Given this list of marker genes TLR5, EIF2AK3, ATP6V1B2, EGR2, ZMIZ1-AS1, EFR3A, UBR7, TDRD9, FAM131A, ATP6V1D, RRAD (RRAD, Ras related glycolysis inhibitor and calcium channel regulator), SLCO4A1, SMIM13, TCEAL3, PPARG (NCBI Gene Id 5468), NRIP3, DPH5, PISD, MMP1, FKBP15, ABCB4, BLMH, SDSL, SNX8, ACVR1, CAMTA2, USP53, ATP6V1G1, CTSL, MAP4K3, GALNT11, TOMM34, MOB1B, SLC9B2, SPP1, DYNLT2B, CRY1, AGAP3, SERTAD2, PACC1, CRTAM, LPL, COL15A1, BCAR3, DDIT3, SNX33, EEA1, TMEM65 (NCBI Gene Id 286052), UBXN7, GNA13, OLIG2 (NCBI Gene Id 10215), ENSG00000215022, NPC1, DCUN1D4, RRAGD, RHOBTB3, AMZ2P1, KLHL21, SIGLEC15, LINC-PINT, DCSTAMP, ST18, RIOX1, HES4, CSTB, TRPM7, ASPH, PRKAG2 (protein kinase AMP-activated non-catalytic subunit gamma 2), LGALS3, DTL, LONRF3, PTPRE, PPFIA1, SPRY2, LINC00856, TBC1D2, RRAGC, TUT7, LRRC8B, CDC42EP3, MELTF, S1PR3, CCR1, TMEM181, ATF3, ZC3HC1, NUDT4, ACSL3, SPRING1, SPAG5, WDFY1, GFOD1, TEX10, CHSY1, CEBPB, ADCK2, SNX9, DAB2, LINC01010, PHF13, GNPDA1, SLC3A2, RMC1, MT1E, CORO1C, ATP6V0D2, UPP1, PI4K2A, PLEKHM1, NAA50, CSF1, LHFPL2, STX4, STX3, MT1X, THAP4, WDR91, ITGAX, BANP, ANKRD10, LBX2-AS1, KLHL6, LYSET, SNAPC1, SPINK1, LONP1, PPP2R5A, MMP19, MT2A, DYRK3, PHACTR2, PLCXD1, ANKRD28, MT1HL1 (NCBI Gene Id 645745), MRGBP, ACOX3, BRI3, SOS1, RRN3P3, BHLHE40, TBC1D7, FBXL5, RASGEF1B, RABGEF1, CD84, SCG5, TLNRD1, HTRA4, RLF, ST3GAL6, TCEAL9, ZNF674-AS1, SCARB2, TMEM38B (transmembrane protein 38B), NR4A2, MAFK, STARD8, RBM15, RGS1, GPCPD1, EDN1, SNUPN, AKIRIN2, GEM, ZNF318, TNFSF14, ZCCHC2, ZSCAN5A, HAVCR2, TNFSF15, NRROS, FNIP2, LY9, SGK1, MOAP1, TMEM268, SYN2, ATP6V1H, UBASH3B, RNF19A, COPRS, CALU, DUSP14 (NCBI Gene Id 116242), PLEKHM2 (pleckstrin homology and RUN domain containing M2), CLN8, ZBTB43, IL36RN, GTF2A1, S100A2, SOWAHC, SH3BP5, SERPINE1, NEU1 (neuraminidase 1), LBH, PLPP3, TRIB1, RHOB, here is a description of the gene set: Human Gene Set: GSE9988_LOW_LPS_VS_ANTI_TREM1_AND_LPS_MONOCYTE_DN Genes down-regulated in comparison of monocytes treated with 1 ng/ml LPS (TLR4 agonist) versus monocytes treated with anti-TREM1 and 5000 ng/ml LPS (TLR4 agonist). studied in species Homo sapiens from publication Dower K, Ellis DK, Saraf K, Jelinsky SA, Lin LL (PMID 18292579) TREM-1 is an orphan immunoreceptor expressed on monocytes, macrophages, and neutrophils. TREM-1 associates with and signals via the adapter protein DAP12/TYROBP, which contains an immunoreceptor tyrosine-based activation motif (ITAM). TREM-1 activation by receptor cross-linking is pro-inflammatory, and can amplify cellular responses to Toll-like receptor (TLR) ligands such as bacterial lipopolysaccharide (LPS). To investigate the cellular consequences of TREM-1 activation, we have characterized global gene expression changes in human monocytes in response to TREM-1 cross-linking in comparison to and combined with LPS. Both TREM-1 activation and LPS up-regulate chemokines, cytokines, matrix metalloproteases, and PTGS/COX2, consistent with a core inflammatory response. However, other immunomodulatory factors are selectively induced, including SPP1 and CSF1 (i.e., M-CSF) by TREM-1 activation and IL-23 and CSF3 (i.e., G-CSF) by LPS. Additionally, cross-talk between TREM-1 activation and LPS occurs on multiple levels. While synergy in GM-CSF protein production is reflected in commensurate mRNA abundance, comparable synergy in IL-1b protein production is not. TREM-1 activation also attenuates the induction of some LPS target genes, including those that encode IL-12 cytokine family subunits. Whereas positive TREM-1 outputs are abolished by the PI3K inhibitor wortmannin, this attenuation is largely PI3K-independent. These experiments provide a detailed analysis of the cellular consequences of TREM-1 activation, and highlight some of the complexity in signal integration between ITAM- and TLR-mediated signaling.